The following is a description of a gene set: First dorsal interossei muscle weakness species: Homo sapiens Human Gene Set: HP_FIRST_DORSAL_INTEROSSEI_MUSCLE_WEAKNESS, and this is the list of marker genes: JAG1, GARS1, SCN1A, ATP1A2, CACNA1A, BSCL2, PRRT2, REEP1